The following is a description of a gene set: Genes predicted to be targets of miRBase v22 microRNA hsa-miR-6811-3p in miRDB v6.0 with MirTarget v4 prediction scores > 80 (high confidence targets). Human Gene Set: MIR6811_3P from publication Chen Y, Wang X (PMID 31504780) species: Homo sapiens, and this is the list of marker genes: POLH, CLN8, NELL2, TFDP1 (transcription factor Dp-1), CIITA, KANSL1L, CHGA, NCKIPSD, APBA1, HTR5A, DLGAP4, CXCL14, HOGA1, RNLS (renalase, FAD dependent amine oxidase), HNRNPF, TPO, SYT1, PPTC7, ST8SIA2, INSM1, SARM1, DCC, INHBA, BZW1, NUDT5, ROCK1, DYNC1LI2, TMEM135, CASQ2, SMOC1, MYO6, RIBC1, ANAPC16, CD28, ALG12, SEPHS1 (NCBI Gene Id 88214), MDGA2, UBE2K, CCDC91, NSUN5, SEMA4C, TNFAIP1, HMGN3 (high mobility group nucleosomal binding domain 3), BMPR1A, SUFU, ARHGEF10 (Rho guanine nucleotide exchange factor 10), EIF4E3, KANSL2, PTBP1 (polypyrimidine tract binding protein 1), MECP2, ONECUT2, SCARA3, FASLG, DTNA, GP2, PBX1, ZNF544